The following is a description of a gene set: Any process that results in a change in state or activity of a cell (in terms of movement, secretion, enzyme production, gene expression, etc.) as a result of deprivation of nourishment. Mouse Gene Set: GOBP_CELLULAR_RESPONSE_TO_STARVATION species: Mus musculus, and this is the list of marker genes: Zc3h12a, Cadps2, Yme1l1, Gabarapl1, Lars1, Foxo3, Suv39h1, Kptn, Atg14, Sh3glb1, Ehmt2, Pik3c2b, Bcl2, Pcsk9, Mcu, Hfe, Fbxo22, Trp53, Angptl4, Ywhaz, Sfrp1, Tbl2 (transducin (beta)-like 2), Nprl3, Prkch (protein kinase C, eta), Wnt9b, Alb, Ppara, Hmox2, Rnf167, Atf2, Gba1, Gabarap, Dap, Wipi2, Sirt1, Mapk1, Rraga, Ripor1, Chka, Prkag1, Ctsl, Sar1b, Kat5, Gas2l1, Fcor, Micu1, Gm14151, Tcf7l2, Rrp8, Map1lc3a, Tnrc6a, Foxa3, Dnajc15, Mfsd2a, Tsc2, Ifi206, Seh1l, Pmaip1, Slc39a5, Becn1, Comt, Plin2, Stk24, Mndal, Vps41, Ulk1, Fas, Ifi214, Pick1, Pdk4, Ppm1d, Gcgr, Mtmr3, Wrn, 4933438K21Rik, Slc2a1, Krt20, Lrrk2, Pak5, Plin3, Klf10, Nfe2l2, Jmy, Cpeb4, Mtor, Higd1a, Eif2s1, Rragb, Pak4 (NCBI Gene Id 70584), Srebf2, Ifi207, Gabarapl2, Rnf152, Nprl2 (NCBI Gene Id 67232), Pak3, Tnfrsf11a (NCBI Gene Id 21934), Sp7, Ttc5, Prkd1, Gpr155, Ifi203, Szt2, Pik3c3, Slco2b1, Lamp2, Pak2, Eif2ak4, Wdr45, Rnase4, Ctsk, Ifi203-ps, Wnt2b, Pck1, Eif2ak3, Pik3c2a, Xpr1, Slc7a5, Eif2ak2, Rragd, Hrk, Mios, Stk26, Inhbb, Nupr2, Rragc, Glul, Wipi1, Pik3r4, Nuak2, Pak1, Elapor1, Trim32, Atf3, Ywhag, Stk-ps2, Fnip1, Map3k5, Asns, Mybbp1a, Zfyve1, Depdc5, Castor1, Atxn3, Bmpr2, Slc39a4, Myod1, Ucp2, Fads1, Bhlha15, Ralb, Upp1, Srebf1, Map1lc3b, Atg7, Tsc1, Itfg2, Prkag2, Wdr59, Rptor, Gck, Cdkn1a, Fos, Gas6, Mapk3, Xbp1, Kics2, Wdr24, Mup1, Mapk8, Prkaa1, Sesn2, Prkaa2, Clec16a, Cartpt, Gcn1, 4921509C19Rik, Atg5 (autophagy related 5), Flcn, Usp33, Hspa5, Slc38a3, Becn2, Ifi209, Myh13, Sesn1, Ifi208, Sesn3, Max, Bmf, Dsc2, Sar1a, Ifi213, Jun, Prkag3, Atg4b, Atf4, Impact, Wnt4, Tfeb, Bmt2, Pak6, Foxo1, Slc38a2, Slc34a1, Tbc1d7, Wdr45b, Ambra1, Smdt1